The following is a description of a gene set: Any process that results in a change in state or activity of a cell (in terms of movement, secretion, enzyme production, gene expression, etc.) as a result of a magnesium ion stimulus. Human Gene Set: GOBP_CELLULAR_RESPONSE_TO_MAGNESIUM_ION studied in species Homo sapiens, and this is the list of marker genes: KCNA1, RYR3, SLC41A1, SLFN14, SMPD3, FBP1, ANK3